The following is a description of a gene set: Mouse Gene Set: REACTOME_MITOCHONDRIAL_TRANSLATION studied in species Mus musculus Mitochondrial translation, and this is the list of marker genes: Mrps18a (mitochondrial ribosomal protein S18A), Mrpl20, Mrpl27, Mrps30, Mrpl28, Gfm1, Aurkaip1, Mrps14, Mrpl55 (mitochondrial ribosomal protein L55), Dap3, Gadd45gip1, Mrps18c, Mrps28, Mrpl57 (NCBI Gene Id 67840), Mrpl41, Mrpl39, Mrps7, Mrpl16, Mrps15, Mrpl54 (mitochondrial ribosomal protein L54), Mrps33, Mrps18b, Mrpl53, Mrpl48 (NCBI Gene Id 78314), Mrps36 (NCBI Gene Id 66128), Mrpl2, Mrps26, Mrpl23, Mrps22, Mrps34, Mrpl58, Mrpl45, Mrpl3, Mrps6, Mrps12, Mrpl10, Mrpl50, Mrpl22, Mrpl38, Mrpl46 (NCBI Gene Id 97381), Mrps35, Gfm2, Mrpl15, Mrpl4, Mrpl51, Mrpl52, Mrps23, Chchd1, Mrps10, Mrps27, Mrpl19, Mrpl12, Mrps24, Mrps9, Mrpl37, Mrpl18, Mrps21, Mrpl43, Mrpl47, Mrpl9, Mrpl24, Mrps31, Mrps2, Mrpl35, Mrps17, Mrps25, Mrpl33, Mrpl36, Mrps11, Mrpl44 (mitochondrial ribosomal protein L44), Ptcd3, Eral1, Mtrf1l, Mrpl32, Mrpl14, Mrpl21, Mrpl40, Mrpl1, Mrps5, Mrpl42, Oxa1l, Mrpl49, Mrrf, Mrpl17, Mrpl11, Mrpl30, Mrps16, Mrpl13, Mrpl34 (NCBI Gene Id 94065)